The following is a description of a gene set: Mouse Gene Set: GOCC_SPLICEOSOMAL_COMPLEX Any of a series of ribonucleoprotein complexes that contain snRNA(s) and small nuclear ribonucleoproteins (snRNPs), and are formed sequentially during the spliceosomal splicing of one or more substrate RNAs, and which also contain the RNA substrate(s) from the initial target RNAs of splicing, the splicing intermediate RNA(s), to the final RNA products. During cis-splicing, the initial target RNA is a single, contiguous RNA transcript, whether mRNA, snoRNA, etc., and the released products are a spliced RNA and an excised intron, generally as a lariat structure. During trans-splicing, there are two initial substrate RNAs, the spliced leader RNA and a pre-mRNA. studied in species Mus musculus, and this is the list of marker genes: Snrpa1, Prpf39, Pabpc1, Rbm5, Snrpd3, Tssc4, Rnf113a2, Zcchc8, Snu13, Snrpn, Dnajc17, Bud13, Mfap1b, Prpf4b, Rnf113a1, Eif4a3, Aqr, Sf3b3, Ddx41, Lsm3, Plrg1, Cwf19l1, Rbmxl2, Tra2a, Srrm2, Snrpg, Gemin2, Cdc5l, Ncl, Rbmyf3, Wdr83 (WD repeat domain containing 83), Pdcd7, Luc7l2, Rbm28, Zmat2, Yju2, Snrnp40, Dhx15, Ddx5, Frg1, Cwc22rt3, Smndc1, Luc7l3, Yju2b, Snrpb, Cdc5lrt7, Cwf19l2 (NCBI Gene Id 70773), Cirbp, Syncrip, Prpf6, Dhx40, Lsm8, Cactin, Eftud2, Snrpd1, Prkrip1, Bcas2, Lsm7, Pnn, Snrpa, Hnrnpm (heterogeneous nuclear ribonucleoprotein M), Cript, Hnrnpk, Prpf8, Ess2, Rbmyf6, Syf2, Sugp1, Hnrnph1, Ptbp2 (polypyrimidine tract binding protein 2), Snrpb2, Sf3a1, Rbm48, Cwc27, Cwc22rt2, Tra2b, Ddx42, Isy1, Luc7l, Sf3b6, Rbm44, Alyref, Rbmx2, Lsm6, Ppil2 (peptidylprolyl isomerase (cyclophilin)-like 2), Clns1a, Lgals3, Hnrnpc, Prpf19, Srsf2, Zmat5, Slu7, Snrpd2, Alyreffm3, Upf1, Khdc4, Eif4a3l1, U2af1l4, Magohb, Htatsf1, Dhx35, Dhx8, Cwc22rt5, Snrnp70, Sf1, Prpf18, Cwc22rt6, Alyreffm11, Alyreffm10, Prpf38a, Akap17b, Hnrnpf, Cdc40, Srsf1, Hnrnpr, Alyreffm7, Armc7, Mfap1a, Rbmyf1, Cdc5lrt8, Hnrnpa3, Ddx23, Rbm3, Prpf40b, Snrpf, Cwc22, Usp39, Bud31, Dhx32, Prpf4, Api5, Rbm41, Srrm1, BC005624, Cwc25, Rbmyf9, Gpatch1, Adar, Ppie, Ddx46, Txnl4b, Hspa8, Zfp830, Ctnnbl1 (NCBI Gene Id 66642, catenin, beta like 1), Snrnp25, Rbmx, Sf3b4, Gm7324, Alyreffm5, Ppil1, Snrnp200, Alyreffm6, Prpf40a, Scnm1, Snw1, Rbmy, Ik, U2af1, Txnl4a, Cdc5lrt9, Zrsr2, Ppil3, Cdc5lrt6, Smu1, Wbp4, Sf3a3, Hnrnpu, Ppih, Gcfc2, Snrnp48, Lsm4, Alyreffm9, Wac, Rbm8a, U2af2, Dhx16, Snrpe, Cwc22rt4, Cdc5lrt10, Sf3b5, Prpf3 (NCBI Gene Id 70767), Lsm2, Rnpc3, Snip1, Zcrb1, Prpf31 (NCBI Gene Id 70126), Hnrnpa2b1, Cwc22rt1, Sart1, Prpf38b, Snrpc, Ybx1, Alyreffm1, Ttf2, Ppwd1, Ddx39b, Raly, Snrnp35, Ppp1r8, Sf3a2, Xab2, Rbm17, Tfip11, Cdc5lrt1, Ccdc12, Magoh, Cwc15, Rbmxl1, Cwc22rt7, Hnrnpa1, Crnkl1, Cdc5lrt4, Lsm5, Rbm8a2, Sf3b2, Snrpert, Alyreffm4, Casc3, Srek1, Eif4a3l2, Sf3b1, Dqx1, Aar2, Gpkow, Alyref2, Tex16, Cdc5lrt5, Phf5a, Rbm22, Alyreffm8, Dhx38, Rheb, Mtrex